Given this list of marker genes SUSD6, CDYL2, EVI2B, PDLIM4, CAPNS2, ZFYVE28, MS4A2, GTSF1, FRRS1L, SLC39A14, DYRK2, TANC1, MITF, SCN3A, COMMD9, PYM1, HCN3, ZNF507, UBE2D1, AP4E1, HINFP, VIPR1, TMEM170B, WNT7A, ALS2CL, SGMS1, ITGB3, RREB1, KREMEN1, SLC29A3, CYP4X1, B3GALNT1, CDC37L1, INPP5B, PAX8, APPL2, PGLYRP2, GRM7, KRTAP15-1, SCML4, TAPT1, LIMS4, ADCY7, ANKRD13D, TIMP2, HPS3, RPH3AL, SPTBN1, DAXX, MMP23B, LIPI, GPR18, TNFRSF1A, CYP2S1, CLDN1, RFLNB, FAM78A, LYPD6B, LYST, GGT1, GUCD1, RAB3D, ZNRF3, NSF, TMEM35A, LGI3, TMEM167B, VCAN (NCBI Gene Id 7902), MYLIP, SLC12A7, FNTB, DUBR, FAM98C, AAK1, SLC16A5, CNGA1, RABGGTA, CCDC30, RCBTB2, SLCO3A1, SAYSD1, NSG2, F12, TMEM63A, VOPP1, ADH1C, PIK3IP1, PCCB, PFKFB2, SLC20A1, CARMIL1, CAP2, REXO5, NFE2L2, CTBP1, PADI6, ATP6V0A2, ATP8A1 (NCBI Gene Id 10396), ANKRD11, WDR81, DUSP6, SHC1, VAMP1, NAP1L4, KCNMB4, ACP3, OTUD1, ADGRL1 (adhesion G protein-coupled receptor L1), MLLT11, APBB3, PTPN6, CCDC71L, GPRC5B, TOLLIP, XKRX (NCBI Gene Id 402415), TDRP, ENC1, OVGP1, NCCRP1, RNF167, P2RX4, SIKE1, MFSD8, UQCC3, C1orf21, TAS2R4 (taste 2 receptor member 4), ALG1, SLC38A9, ANKRD23, HERC3, INMT, SOS1, FCGRT, AP3D1, NRK, MINDY3, ELOVL7, CNOT3, WIPF2, RHOT2, REV3L, CLIP1, ODAM (NCBI Gene Id 54959), KCTD8, CHD7, ZZEF1, ENSG00000267882, KPRP, EGR1, SRSF12, ACVR1B, ZFP36, SETD4, EIF2AK3, IGSF1, ZCCHC12, ACAP1, LRRN4CL, EXPH5 (NCBI Gene Id 23086), SGK1, CTDSP2, FAM120AOS, USP40, DENND2D, NPC2, RAPGEF4, IL1RL2, MAP3K7, PPP1R13B, EPB41, DNAH9, FZD6, ELAVL3, KBTBD7 (kelch repeat and BTB domain containing 7), EEIG1, TMEM241, TET1, MTUS2, THEMIS, UBD, ARL4C, SATB1, SEMA4G, TMEM86A, PIP4K2A, ZNF446, ADRB2 (adrenoceptor beta 2), MAN1A2, RNASE6, CPM, FGA, GRK6, ARHGAP29, FCRLA, RAP2C, SRR, DMTF1, ITGB5, SLC9A6, here is a description of the gene set: from publication Feuerer M, Herrero L, Cipolletta D, Naaz A, Wong J, Nayer A, Lee J, Goldfine AB, Benoist C, Shoelson S, Mathis D (PMID 19633656) Human Gene Set: GSE7852_TREG_VS_TCONV_THYMUS_DN studied in species Homo sapiens Comparisons of global gene-expression profiles revealed a greater distinction between CD4+ Treg cells and CD4+ conventional (Tconv) T cells residing in abdominal (epidydimal) fat versus in more standard locations such as the spleen, thymus and LN. Genes down-regulated in comparison of thymus regulatory T cells versus thymus conventional T cells.